The following is a description of a gene set: species: Homo sapiens Human Gene Set: OHASHI_AURKB_TARGETS Mammalian Aurora-A is related to a serine/threonine protein kinase that was originally identified by its close homology with Saccharomyces cerevisiae Ipl1p and Drosophila melanogaster aurora that are key regulators in the orchestration of mitotic events. The protein level of Aurora-A, its peak kinase activity during mitosis, and its activation have been attributed to phosphorylation. Here we show that this enzyme is an arginine-directed kinase and define its substrate specificity. We also found that Thr288 within the activation loop is a critical residue for activating phosphorylation events in vitro and that it is spatiotemporally restricted to a brief window at mitosis on duplicated centrosomes and on spindle microtubules proximal to the poles in vivo. Immunodepletion assays indicated that an upstream kinase(s) of Aurora-A might exist in mammalian cells in addition to autophosphorylation. Furthermore, human activated Aurora-A forms complexes with the negative regulator protein serine/threonine phosphatase type 1 (PP1) that was negatively phosphorylated on Thr320. Interestingly, phospho-specific Aurora-A monoclonal antibodies restrain Aurora-A kinase activity in vitro, providing further therapeutic avenues to explore. Candidate substrate proteins of AURKB. from publication Ohashi S, Sakashita G, Ban R, Nagasawa M, Matsuzaki H, Murata Y, Taniguchi H, Shima H, Furukawa K, Urano T (PMID 16785988), and this is the list of marker genes: H3C15, RACGAP1, KIF2C, INCENP, CENPA, AURKB, VIM, DES